The following is a description of a gene set: Human Gene Set: GOBP_RHYTHMIC_PROCESS Any process pertinent to the generation and maintenance of rhythms in the physiology of an organism. species: Homo sapiens, and this is the list of marker genes: CSNK1E, STAT5B, F7, NTRK3, LHCGR, TYRO3, CAVIN3, TNFAIP6, PASD1, NPPC, ADNP, ADORA2A, SPSB4, OPRK1, DDB1, ROBO2, DNM1L, OPN5, NFILZ, GABRB1, FBXL3, NFKB2, AMH, LEP, ATG7, NMU (NCBI Gene Id 10874), ZFHX3, SIN3A, PDE6B, NPY5R, OPN3, SERPINF1, CCAR2, MAPK9, ESR1, NGFR, FBXW11, MMP2, EREG, FSHR, MYBBP1A, HNF4A, GHRL, C3orf70, RPE65 (NCBI Gene Id 6121), NOS3, NDUFA9, KLF10, LGR4, ID3, ID4, SIK1, DRD2, KCNA2, COL6A1, FBXL21P, DBP, PML, NOS2 (NCBI Gene Id 4843), SLC6A4, ZP3, PROKR1, MAGED1, SETX, OPN4, ZNF830, FZD4, DHX9, ZPBP2, NR1D1 (nuclear receptor subfamily 1 group D member 1), PTPRN, ADCY1, PRKCG, TARDBP, PTX3, SOX14, SIX3, HNRNPU, CDK5R1, ADORA1, PPP1CA, AFP, EZH2, AGRP, NPR2, HUWE1, CSF2, MTOR, TOP1, BMAL1, EGR3, IGF1, PROX1, DRD3, PRMT5, TGFB2, RORA, MDK, NCOR1, CRH, JUND, NUDT12, TNFRSF11A, RORB, METTL3, UBE3A, PPP1CB, MSTN, PSPC1, CASP2, BTBD9, SREBF1, RBM4, PRKAA2, TEF, NR1D2, BHLHE40, KLF9, PTN, NAGLU, GABRB3, FOXO3, CLDN4, TIMELESS, MMP19, PTEN, PIWIL2, DRD4, CBX3, PGR, BLOC1S6, CIPC, NCOR2, PPP1CC, PPARGC1A, PCNA, DYRK1A, SLC26A6, BECN1 (beclin 1), SUV39H2, HCRTR2, BMPR1B, KMT2A, ROCK2, HEBP1, GNRH1, ENOX2, PHLPP1, NTRK1, CRY2, PRKG1, FSHB, EP300, CASP3, SGPL1, ENOX1, HTR7, NTRK2, PARP1, PROKR2, STAT5A, GSK3B, CREB1, KCND2, NFIL3, HES7, SCN9A, SUV39H1, PPARA, NGF, NR5A2, USP7, RACK1, KAT2B, USP2, CHRNB2, PTGDS, NR5A1 (NCBI Gene Id 2516), SCAPER, NLGN1, PER1 (period circadian regulator 1), AANAT, SIRT6, MYCBP2, ANKFN1, BTRC, PROK2, SLIT2, GPR157, BMAL2, CREBBP, NR2F6, GNAQ, MTNR1A, SLIT3, CGA, NOTCH4, KDM8, MAGEL2, TGFB3, MC3R, ADAMTS1, PER2, MTA1, ABCB1, HDAC3, GPR176, NONO, RETN, SIRT1, GPR149, ASS1, GHRHR, PRKAA1, KDM2A, ATOH7, PLEKHA1, HAS2, KDM5B, NPY2R, CUL4A, OGT, RBM4B (NCBI Gene Id 83759), NRIP1, SP1, INHBA, NHLH2 (NCBI Gene Id 90888), CSNK1D, CIART, CA12, ATF4, CLOCK, PRKDC, KDM5C, MAPK8, CSNK2A1, NR0B2, GFPT1, CREM, NAMPT, SFPQ, GAS2, MAPK10, SRRD, GDF9, RAI1, DDX5, AHR, ID1, MTTP, SCN11A, DTL, NPAS2, GHRH, SIAH2, CDK5, PER3, NOCT, ID2, NFYA, PDGFRA, CRY1, PPARG, KDM5A, NOTCH1, TP53, ROGDI, ATF5, FBXW7, GRIN3A, RORC, HNRNPD, ADIPOQ, PLN, TOP2A, NR1H3 (nuclear receptor subfamily 1 group H member 3), AXL, THRAP3, TWIST1, HDAC1, NCOA2, NKX2-1, GDF10, MTNR1B, CDK1 (NCBI Gene Id 983), FXR1, HDAC2, TNF (NCBI Gene Id 7124), CARTPT, NCOA1, EGR1, BHLHE41, NPS, GNA11 (G protein subunit alpha 11), ADRB1, RELB, HLF, CRTC1, IMPDH2, KAT5, USP9X